Given this list of marker genes Trim75, Mlh3, Fbxo5, Aurka, Meioc, Ubb, Ccnb2, Brme1, Ndc80, Cenpe, Trip13, Hsf2bp, Cdc25b, Meiob, here is a description of the gene set: Mouse Gene Set: GOBP_FEMALE_MEIOSIS_I species: Mus musculus The cell cycle process in which the first meiotic division occurs in the female germline.